Given this list of marker genes Pknox1, Tgfb2, Prr14l, Rbpjl, Rab6a, Efcab11, Nfx1, Etv2, Srebf1, Ercc1, Ccni, Sfrp1, Vsig10, Mga, Txnrd2, Pttg1ip, Mrps35, Iftap, Mtag2 (metastasis associated gene 2), Ncoa3, Zfp54, Drd1, Pdzrn3, Atp6v0a2, Il15, Pus1, Supt6, Gpc5, Dusp5, Selplg, Phf21b, Rap1a, Preb, Oc90, Lrrc7, Gm5535, Dtx1, Coro1c, C1qtnf1, Caps2, Selenos, Gm11205, Ccser2, Bnc2, Nfe2l1, Sema3g, Appl2, Prom2, Wnt5a, Eef1d, Stx16, Tuft1, Eomes, Arrdc3, Crhbp, Tor4a, Gmpr, Erbb3, Slc38a10, 9630001P10Rik, Serpinh1, Cobl, 4930429F24Rik, Sec31a, Ube2d3, Gm38247, Mir3081, Adgrb1, Ryr3, Gm19569, Gm22297, Alas1, Sec31b, Acad9, Gm4482, Vwa5b2, Zdhhc18, Dmrtb1, Ehmt1, Srsf4, Gm26973, Ipo13, Med27, Mtf2, Gm6801, Ly6h, Acaa2, Ikbke, Iqcf4, Rgs19, Ccdc18, Mis12, Kdelr2, Cacng2, Rrp9, Prr35, Ubxn2a, Parvb, Plekhf2, Rasal2, Mast4, Alkbh1, Sh3kbp1, Zfp219, Nell2 (NCBI Gene Id 98001), Lhpp, Plxna2, Tlx1, Ift88, Gpbp1l1, Ptprn, Dus1l, 4930539J05Rik, Lamr1-ps1, Stx17, 9630013D21Rik, Abr, Ndel1, Lfng, Ktn1, Fbxo42, Mrps18b, Coro2a, Mis18a, 2010109A12Rik, Stx12, Bsg, Gm8731, Nagpa, Polr1d, Zap70, Wipf1, Ergic3, Megf9, Cfap100, Anp32b, Derl2, Il2ra, Zc3h14, Mdk (NCBI Gene Id 17242), Cbarp, Kmt2e, A930001C03Rik, Slc6a6, Bclaf3, Scd1, Hira, Aplf, Col27a1, Igkj5, Gm22236, Gldn, Tbc1d9b, Lkaaear1, Mir695, Tbx15, Isl1, Elf5, Shisa6, Tsga13, Hmgb1, B4galt2, Antkmt, Rnf157, Cisd1, Mir6339, H19, Arhgef25, Dusp6, Spns2, Cep78, Ccdc136, Snora17, Slc22a15, Trpm1, Cspp1, Dlg4, Gpam, Aqr, Krt18, Ubr4, Bola1, AI839979, Crtc3, Rbm5, Ifi44, Fbxw9, Cenpe, Foxn4, Glra1, Kcnq2, Slc52a2 (solute carrier protein 52, member 2), Sytl3, Fndc4 (fibronectin type III domain containing 4), Uckl1os, Aqp9, Sohlh2, 1700063H04Rik, Ddx43, Gm29514, Niban2, Slc1a3, Bok, Fgfr1op2, Msh5, Polr1h, Mif4gd, Uros, Abcc1, Sult4a1, Aff4, Arih2 (NCBI Gene Id 23807), Dstyk, Numbl, Dclk1, Mapkbp1, 1600014C23Rik, Slc5a2, Nek8, Stard4, Frmd5, Zfp146, Bysl (NCBI Gene Id 53955), Etfbkmt, Ogfod2, Ncbp2, Ncam2, Ninl, Stt3a, Aff3, Myh14, Dcun1d3, Rnf166 (NCBI Gene Id 68718), Opcml, Ppfia1, Lamb2, Slc24a2, B130046B21Rik, Gm22154, Cdk20, 9330175E14Rik, Slc12a4, Bpifa1, Zfp787 (zinc finger protein 787), 4921504A21Rik, Zbtb18, Ewsr1, Jade1, Slc30a3 (solute carrier family 30 (zinc transporter), member 3), Mir615, C230057A21Rik, Trak1, Gm25150, Akt1, 5330411J11Rik, Ighv5-9, Snhg7os (small nucleolar RNA host gene 7, opposite strand), Gm6139, Hspb1, Eras, Nudt9, Kmt2a, Or51h5, Ubqln4, Ints10 (integrator complex subunit 10), Rgs11, Dnajc13, Strip2 (NCBI Gene Id 320609), Eeig2, 6430710C18Rik, Kif12, H6pd (NCBI Gene Id 14379), Txnl4a, 4930556M19Rik, Hrh3, E2f4, Slc9b2, Mfsd10, Pvt1 (Pvt1 oncogene), Fank1, Msrb3, Smc1b, Chrna9, Ank, Rab20, A430057M04Rik, Uck2, Clec11a, Mocos, 9130410C08Rik, Rmc1, Ube2l3, 4930470P17Rik, Atp6v0a1, Fus, Shox2, Slc12a5, Cdk6, Tmem65, Dtl, Ift43, Dnmt3l, Pramel6, Prxl2b, Serhl, Rnf181, Gm26070, Fsd1l, Cacna1g, 5730455P16Rik, Ftcd, Ap3m2, Ptprtos, 4833422C13Rik, P4ha2, Bnip1, Rps2, Snx15, Zfp133-ps, Rbm25, Gm13400, Apoc3, Scarna2, Csnk1a1, Cep162, Pax2, AF357399, Plagl2, Plk4 (NCBI Gene Id 99606), Nmi (N-myc (and STAT) interactor), Gm14455, Aqp5, Mir7241, Gm3563, Slc1a4, Mir6941, 1700040D17Rik, Slc25a22, Pkp3, Def8, 2610307P16Rik, Sds, Jag1, Pttg1, Cog2, Tbc1d9, H2-T24, Tmcc3, Bambi, Gm24223, Col2a1, Taf6l, F630040K05Rik, Tmem81, Pcnx3, Mir7036b, Tubb3, Pemt, Ednra, Slc24a4, Alkbh6, Mterf4, Septin3, Ctu2 (NCBI Gene Id 66965), Ubiad1 (UbiA prenyltransferase domain containing 1), Ifitm7, Gm15469, Shisa4, Tenm3, Tardbp, Vps35l, Eme2, Gm15972, Nek4, Dppa3, Selenop, Tmbim4, St8sia2, Fbf1, Bahd1, Gramd1b, T, Phldb1, Tbck, Exosc2, Scx, Leo1, Gm5113, Swt1, Relt, Pcmtd2, Gm9920, Epha7, Gm16148, Safb2, Zfp335os, Tubg2, Ube2r2, Ints13, Ldha, Sft2d3, Prmt3 (NCBI Gene Id 71974), Canx (calnexin), Dnmt3a, Naa25, Dhx32, Gm28447, Evc, Mmp23, Sema5b, Grsf1, 1700039E22Rik (RIKEN cDNA 1700039E22 gene), Atp8b2, Opn5 (NCBI Gene Id 353344), Hoxd3, Pgbd1, Cd24a, Rgs7, Arf2, Shroom3, Svop, Ccdc71l, Pcdh1, Guca2b, Tdrkh, Dot1l, Nfam1, Sdad1, Scgb2b24, Slc16a3, Fam178b, Treh, Hap1, Baz2b, Zfp872, Fgf9, Rbm46os, Scn8a, Amhr2, Blmh (bleomycin hydrolase), Tdpoz2, Uckl1, Gm13033, Pias3, Rbm15b, Mir202, H2-Q3, Cnr2, AA386476, Tvp23bos, Rbpms, Rapgef3, Gm14486, Fam171b, Gpr88, Foxp2, Gm4221, Gm4617, Gm12676, Nipal2, Sh2b3, Hoxa7, Maf1, Gm25260 (predicted gene, 25260), Slc39a14, Polr2a, Litafd (NCBI Gene Id 436336), Fgfr1, Ppp1r11 (protein phosphatase 1, regulatory inhibitor subunit 11), Topaz1, Efhb, Gm22879, Smpdl3b, Naa12, Bms1, Naa15, Ror2, Gm11579, Sema3f, Gm11789, Gemin5, Tmem97, Ces3b, Gm25650 (NCBI Gene Id 115487529), Gstt3, Dgkd, Fam43a, 8030474K03Rik, Fli1, Barx1, Anxa9, Rimklb, Fgf8, Ppp1r9a, Cops5, Stpg2, Map3k11, Trappc3l, Tulp1, D630024D03Rik (NCBI Gene Id 414116), Armh4, Axin2, Cish (cytokine inducible SH2-containing protein), Myom2, Mir7215, Vil1, Gigyf2, Rps6ka1, Fam8a1, Gm28153, Gm26682, Adamts14, Fam20a, Car11, Snord14a, Tmem144, Cars1, E230015B07Rik, Yme1l1, Mettl17, Fez1, 1700013H16Rik, 6430550D23Rik, Slc2a5, Necap2, Enpp3, 1700041G16Rik, 2210408F21Rik, Ube2j1, Acvr1b, Nelfe, Gm28535, Uggt1, Sez6, Wrap73, Sgpl1, Ccdc40 (NCBI Gene Id 277022), Strn4, Magohb, Gm6054, Entpd6, Gm13431, Fntb, Efna1, Plekha7, Cdk15, Epo, Prpf38b, Crtac1, Gatad2a, Gad2, Zfp867, Mmd2, Ppa2, Fadd, 1700030M09Rik, Pgbd5, Tmprss12, Cdkn3, Mir6968, Ippk, Trappc6a, Spns1, Dock2, Odad1, Sema6d, Pax8, Fam98c (family with sequence similarity 98, member C), Mta2, Tagln, Hrh1, Pou6f1, S100a6, Gm12353, Gm17767, Tatdn2 (NCBI Gene Id 381801), Mib1, Nsmce4a, Zfand2b, Tbc1d1, Tmem82, Ankrd24, Flvcr1, Resf1, Rad54l2, Fhl2, Gfi1b, Zfp512b, Dnttip1, Lrba, Nomo1, Dusp13b, Trank1, Tjp3, Rasgrf2, Mepce, Nuak1, Exoc3l, Gm25185, Tdp1, Gm4779, Kcnh2, Rbm46, 2810039B14Rik, Gpx4, 9530036O11Rik, Magi2, Mrs2, Erp44, Gm16001, Kpna7, Gm23119, Usp53, Tor1aip1, Cnot10, Srprb, Wfdc3, Alk, Zfp513, Snap29, Gfpt2, Gm24233, Ccdc42, Neil2, Dnajb8, Capn5, Bckdk, Hspa1b, Rgs3, Bst1, Ankrd13d, Vars2, Gm26256, Pnisr, Tspoap1, Pus3, C330018D20Rik, Mad1l1, Snx12, Ntaq1, Atp11a, Pkhd1l1, Lrrc1, Gm34583, Rpl7a, Hopxos, 1110002L01Rik, Aqp7, Sumo1, H1f0, Efna5, Ino80b, Ptch2, Ankhd1, Ldlrap1, Gabbr2, Pitpnc1, Rgl3, Chpf, D430041D05Rik, Hnrnpd, Ccnq, Smtn, Rreb1, Ankrd44, Sis, Arhgef10l, Lpgat1, Gm12678, Eif1ax, Obsl1, Mastl, Sirt4, Mroh5, Prkcd, Gm16617, Npas4, Zrsr2, Hs3st1, Fryl, Urb2, Ipo11, Tnik, Mtmr1, Gm13816, Samd4 (sterile alpha motif domain containing 4), Lypd1, Tmbim1, Gm13344, Aim2, Gja5, Cnga3, Pot1a, Pxylp1, Zfp644, Col11a2, Zkscan5, Usp36, Med22, Nrdc, Tmbim6, Chd5, 1810021B22Rik, Fos, Arfgef1, Nbeal2, Acox3, Ddx51, Kif2c, Ldb1, Rmi2, Lnx2, Eno4, Zmat2, Stat6, Klhl28, St6gal1, 2310022A10Rik, Mir6907, Dmpk, Csdc2, Lrrc27, Trip4, n-R5s41, Togaram1, Gm5272, Plekhb2, Cdk16, Fcor (Foxo1 corepressor), Zfp318, Pou4f1, Dhx30 (DExH-box helicase 30), Tmem131l (NCBI Gene Id 229473), Zfp608, 1700028D13Rik, Csrp2, Bri3bp, Pitpnm2, Ift46, 4933406I18Rik, Llgl1, Gm16551, Iqgap3, Mllt11, Dcp1b, Cacng4, 4930528J11Rik, Map4, Mir129-2, Ankrd63, Cerox1, Dnaaf1, Nisch, Tcp11, Fam169a, Rhbdl1, Ola1, Vmn2r-ps60, Srrm2, Arhgap27, Pld3, Abcf1, Mybl1 (NCBI Gene Id 17864), 4930532M18Rik, Tdh, Scamp1, Zfp507, Gm29538, Dst, Pisd, Lca5, Dusp7, Gm24641, Acly, Map3k7, Rgs12, Rfx4, Samd13, Taf5l, Fam169b, Arid3b, Trim33, Rnf130, Sox1ot, Trp53bp2, Alad, Catsper4, Mir7686, Uprt, Gtf2ird2, Caprin1, Gm2044, Tbc1d17, Myo7a, Rtn1, Gm15270, Gm28035, Gm24620, Pygb, Bmf, Scarna17, H2bc21, Gm18018, Stard3nl, Gm2093, Eef2k, Slc35b2, Rit2, Sox8 (SRY (sex determining region Y)-box 8), Tfam, Gm10837, Ahnak, E330023G01Rik (RIKEN cDNA E330023G01 gene), Slc7a7, Eif4ebp2, Matk, 4833428L15Rik, Crebrf, Mapk8ip2, Tfb2m, Gm16505, Mboat7, Map2k2, Gorasp2, Dhps, 2810025M15Rik, Ppfibp1, Gm6184, Mir7051, Mir6977, Fam227b, C130060C02Rik, Myl1, Rprd1a, Zcwpw1, Hyal2, Zpbp2, H3f3a, Dnai4, Gm9569, Ddx25 (DEAD box helicase 25), Slc29a4 (NCBI Gene Id 381743), Tpbg, Kdm6b, Gm8618, Gm37125, Mapre2, 2510039O18Rik, Ighg2b, Sft2d1, Smarcb1, Gm24965, Ncbp2as2 (Ncbp2 antisense 2 (head to head)), Map2k7, Cdpf1, Fubp1, Mkx, Rhod, Gm12741, Tmem198, Kpna6, Pi4ka, Col15a1, Cerkl, Gna14, Gm9917, Dlgap3, Rusc2, Tpsg1, Aacs, Crnkl1, Ing2, Rell2, Snora68 (small nucleolar RNA, H/ACA box 68), Ankdd1a, Synj2, Adgrl2, Ifrd2, here is a description of the gene set: Mouse Gene Set: NPM1_TARGET_GENES studied in species Mus musculus Genes containing one or more binding sites for (Npm1) in their promoter regions (TSS -1000,+100 bp) as identified by GTRD version 20.06 ChIP-seq harmonization. from publication Yevshin I, Sharipov R, Kolmykov S, Kondrakhin Y, Kolpakov F (PMID 30445619)